Given this list of marker genes PRELID1, PITPNA, PITPNM3, GLTPD2 (glycolipid transfer protein domain containing 2), CERT1, ABCA3, MTTP, PLTP, CPTP, PRELID2, PLEKHA8P1, PRELID3A, TNFAIP8L3, SCP2 (sterol carrier protein 2), PITPNC1, PITPNM1, BLTP1, GLTP, TMEM63B, TRIAP1, PITPNM2, OSBPL2, ESYT1, C2CD2L (C2CD2 like), PLEKHA8, PITPNB, PRELID3B, here is a description of the gene set: Human Gene Set: GOMF_PHOSPHOLIPID_TRANSFER_ACTIVITY Removes a phospholipid from a membrane or a monolayer lipid particle, transports it through the aqueous phase while protected in a hydrophobic pocket, and brings it to an acceptor membrane or lipid particle. studied in species Homo sapiens